The following is a description of a gene set: Mouse Gene Set: GOCC_PLATELET_ALPHA_GRANULE A secretory organelle found in blood platelets, which is unique in that it exhibits further compartmentalization and acquires its protein content via two distinct mechanisms: (1) biosynthesis predominantly at the megakaryocyte (MK) level (with some vestigial platelet synthesis) (e.g. platelet factor 4) and (2) endocytosis and pinocytosis at both the MK and circulating platelet levels (e.g. fibrinogen (Fg) and IgG). studied in species Mus musculus, and this is the list of marker genes: Fgg, Fga, Pf4, Snca, Vps33b, Mmrn1, Fgb, Stxbp3, Stxbp1, Ppbp, Igfbp3, Treml1, Sparc, Serpina5, Igf1, F5, Thbs2, Selp, Thbs1, Serpine2 (serine (or cysteine) peptidase inhibitor, clade E, member 2)